Given this list of marker genes SPDYE6, ZNF497, GRK1, AVL9, SEC22A, SPDYE5, SPDYE1, SH3BP5, TTC31, DMD, here is a description of the gene set: Genes predicted to be targets of miRBase v22 microRNA hsa-miR-6863 in miRDB v6.0 with MirTarget v4 prediction scores > 80 (high confidence targets). from publication Chen Y, Wang X (PMID 31504780) Human Gene Set: MIR6863 studied in species Homo sapiens